Given this list of marker genes SLC22A6, SLC26A2, SLC4A9, CLCN7, SLC4A3, SLC26A7, SLC26A11, SLC26A6, SLC25A14, SLC4A2, SLC37A1, SLC26A5, SLC25A24, SLC26A8, SLC25A23, SLC4A5, SLC4A1, SLC26A1, SLC22A11, SLC37A2, SLC4A11, SLC4A10, SLC26A9, SLC4A8, SLC26A4, SLC4A4, SLC4A7, SLC25A30, CLCN3, SLC37A3, SLC22A8, SLC37A4 (NCBI Gene Id 84965), SLC26A3, SLC25A25, here is a description of the gene set: Enables the transfer of a solute or solutes from one side of a membrane to the other according to the reaction: inorganic anion(out) + solute(in) = inorganic anion (in) + solute(out). species: Homo sapiens Human Gene Set: GOMF_SOLUTE_INORGANIC_ANION_ANTIPORTER_ACTIVITY